Given this list of marker genes CD244, CIITA, SLC22A4, IL10, TTR (NCBI Gene Id 7276), PTPN22, NFKBIL1, here is a description of the gene set: studied in species Homo sapiens Digital flexor tenosynovitis Inflammation of the flexor digitorum tendon, often associated with the Kanavel signs: (i) finger held in slight flexion, (ii) fusiform swelling, (iii) tenderness along the flexor tendon sheath, and (iv) pain with passive extension of the digit. Human Gene Set: HP_DIGITAL_FLEXOR_TENOSYNOVITIS